Given this list of marker genes NDUFB11, ATP1A3, ATP6V0A1, EXOSC1, OPA1, CERS1, TBC1D23 (TBC1 domain family member 23), B4GAT1, MYMK, KRIT1, TSEN54, MARS2 (methionyl-tRNA synthetase 2, mitochondrial), LMNB1, WDR73, FA2H, CASK, DISP1, DNM1L, NDUFAF5, SLC25A46, DLL1, PPP2CA, ETHE1, PMPCB, WARS2, PMM2, MAPK10, MED23, THSD1, LAMA2, EXOSC3, PNKP, COASY, FGF8, ATXN8OS, CLTC (NCBI Gene Id 9511), GMPPB, DAG1, NUBPL, PTEN, PYCR2, TGFBR3, NDUFV1, STIL, DKK1, RARS2, GET4, NDUFB3, NDUFS8, ABCD1, TOE1, MDH1, ARHGEF2, EN1, CRIPTO, B3GALNT2, FOXH1, LYRM7, TRMT10A, GNAO1, SPTAN1, KIFBP, SMPD4, EXOC2, NDUFA1, INPP5E, PIGA, TUBB, ROBO3 (roundabout guidance receptor 3), VLDLR, TRAF7, DEGS1, NDUFB10, COL3A1, SCO2, SLC19A3, STAG2, DEPDC5, TMEM216, MED17, ROBO1, PI4KA, DPM1, FKRP, CEP55, TMEM126B, MT-ND3, PIEZO2, RANBP2, SMO, RPGRIP1L, ALG3, NDUFS2, ASXL1, TSEN15, EXOC7, PDHX (pyruvate dehydrogenase complex component X), CCDC88C, CDON, DOCK7, SETD2, NDUFS1, SMARCE1, TMEM67, GABRB3, CHMP1A, NDUFV2, ATXN2, MT-ND1, PRDM13, TMEM237, GLI2, AMPD2, TUBB3, KPNA3, ZIC2, CTNNA2 (catenin alpha 2), SMARCA2, SIX3, AHI1, NDE1, DYRK1A (dual specificity tyrosine phosphorylation regulated kinase 1A), NDUFA6, SMC1A, POMT1, ARL3, TWNK, RORA, SUFU, MTRFR, TSEN34, DNAJC19, TSEN2, TIMMDC1, POMGNT1 (protein O-linked mannose N-acetylglucosaminyltransferase 1 (beta 1,2-)), PCLO, PRDX3, IDH1, CLP1, FKTN, CYP27A1, TUBB2A, NDUFAF3, SCN1A, MAB21L1, FARS2, PDHB, BLTP1, TUBA1A, APC2, ATP7B, NDUFAF8, TBCD, GPHN, NDUFS3, TMX2, DNAJC3, PPIL1, POMT2, ITPR1, SHH, NDUFAF2, ENSG00000288330, ELOVL5, COG8, GFAP, AHCY, CHD2, TBP, COG5, GALC, CLCN3, CACNA1A, FLVCR2, AIFM1, CRPPA, FH, MYH3, TGIF1, PAFAH1B1, EXOSC9, BAP1, TUBA8, SEPSECS, NODAL, GFM2, NF2, ADCY5, NPHP1, PIK3CA, NDUFA11, TRRAP, FMR1, PIGS, STUB1, PLCH1, BRF1, UBE2A, NDUFAF1, NSRP1, CACNA1G, CSPP1, RAC1, LAMA1, LARGE1, FLI1, CDC40, FTH1, AHDC1, TNFRSF11A, FGFR1, GTPBP3, NDUFS6, PPP1R15B, PDGFB, TMTC3, SACS, SLC5A6, VPS4A, POLR1A, VRK1 (VRK serine/threonine kinase 1), ANGPTL6 (NCBI Gene Id 83854), MFSD2A (MFSD2 lysolipid transporter A, lysophospholipid), SNX14, WNT1, EIF4A2, SETX, TERT, MTRR, PTCH1, ZIC1 (NCBI Gene Id 7545), MACF1, RNASEH1, CUX2, EPG5, RAB11B, POGZ, MT-ND2, VPS51, INTS11, MAST1, TRAPPC6B, SMARCB1, ZNHIT3, DCC, NDUFS4, FGFR3, RTTN, NDUFS7, CCM2, PI4K2A, USP9X, PPP2R1A, LAMB1, AGTPBP1, ASNS, KIAA0586, SLC35A2, ADGRG1, ENG, AKT1, PLK4, DYNC1H1, NDUFB9, DNM1, DNMT1, NAGA, ECHS1, NFIX, SYNE1, POMK, PDCD10, ATXN1, RERE, CEP290, TUBB2B, MINPP1, ABCB7, GAS1, EXOSC8, CIT, NDUFAF4, DYNC1I2, RELN, FOXRED1, TRAPPC12, here is a description of the gene set: Abnormal brainstem morphology species: Homo sapiens Human Gene Set: HP_ABNORMAL_BRAINSTEM_MORPHOLOGY An anomaly of the brainstem.